The following is a description of a gene set: Mouse Gene Set: GOCC_COLLAGEN_CONTAINING_EXTRACELLULAR_MATRIX An extracellular matrix consisting mainly of proteins (especially collagen) and glycosaminoglycans (mostly as proteoglycans) that provides not only essential physical scaffolding for the cellular constituents but can also initiate crucial biochemical and biomechanical cues required for tissue morphogenesis, differentiation and homeostasis. The components are secreted by cells in the vicinity and form a sheet underlying or overlying cells such as endothelial and epithelial cells. species: Mus musculus, and this is the list of marker genes: Adamts17, Col28a1, Angpt4, Tgfb1, F3, Insl5, Nid1, S100a3, Pf4, Mfge8, Fga, Vwa1, Hapln4, Krt1, Fibcd1, Zp3, Efemp1, Adamts4, Adamts5, Agrn, Prss2, Spock2, Mfap5, Snorc, Vcan, Sparc, Bgn, Sparcl1, Anxa7, Postn, Fgfr2, Gpc2, Hnrnpm, Zg16, Abi3bp, Mfap1b, Rtbdn, Gpc4, Anxa4, Cela1, Dspp, Plod2, Ccn3, Il16, Lama3, Srpx2, Fgf10, Egfl7 (EGF-like domain 7), S100a11, Plod1, Adamtsl4, Ltbp1, Serpina3k, Lamb3, Mmp9, Hcfc1, Plxdc2, Serpinb1a, Htra1, Thbs4, Pzp, Rpsa, Pkm, Otol1, Ins2, Plscr1 (NCBI Gene Id 54533), Impg2, Sod3, Col14a1, Sftpa1, Matn2, Frem1, Adamts2 (NCBI Gene Id 327918), Col4a4, Ltbp3 (NCBI Gene Id 16998), Ctsb, Bmper (NCBI Gene Id 73230), Ncan, Ngly1, Lamc2, Tgm2, Mgp, Serpina1a, Lrrc15, Gpc1, Scara3, Muc2, Col24a1, Angptl1, Anxa6, Pcsk6, Itih2, Ambp, Aspn, Lgals1, Lama2, Col20a1, Serpine1, Tgm4, Col3a1 (collagen, type III, alpha 1), Cst3, Loxl3 (lysyl oxidase-like 3), Lamc1, Ctsc, Myoc, Ltbp4, Kng1, Mfap4, Emilin1 (elastin microfibril interfacer 1), Col17a1, Fn1, Cpn2 (carboxypeptidase N, polypeptide 2), Tgm3, Col4a3, Loxl1, Matn1, Reg2, Hsp90aa1, Fbn2, Col13a1, Gpc5, Tnn, Col6a6, Col7a1, Anxa9, Bmp7, Ecm1 (extracellular matrix protein 1), Comp, Sema3c (sema domain, immunoglobulin domain (Ig), short basic domain, secreted, (semaphorin) 3C), F13a1, Slit2, Gpc6, Tinagl1, Cspg4, Hmcn1, Vwf, Mfap1a, Igfbpl1, Hrg, Lum, Anxa2, Vwc2, Fam20b, Pcolce2, Tgfb3, Nid2, Cela3b, Adam19, Angptl6, Egflam, Col11a1, Bcan, Fbn1, Podnl1, Sspo, Adamts8, Serpinh1, Ctsd, Ctsl, Col8a1, Plod3, Ins1, Col23a1 (NCBI Gene Id 72794), S100a10, Lamb1, Igfbp7, Sftpb, Thbs3, Zp1, Emilin2 (elastin microfibril interfacer 2), Mmrn1, Dmbt1, Prelp, Wnt2, Loxl2, Cilp, Col9a1, Col12a1, Lgalsl, Lama4, Adamts1, Hmcn2, Reln, Lman1, Reg1, Col1a1, Prg4, Hspg2, Col4a2, F2, Tgfbi, Igf1, Col19a1, Calr, Angptl2, Tspan9, Lama1, Ccn1, Colq, Col10a1, Pxdn, Col11a2, Kazald1, Thbs1, Clec14a, Sftpd, Col6a1, Ccdc80, Nav2, Frem2, Serpine2, Tgfb2, Ctsz, Ecm2, Col4a1, Adamts10, Mamdc2, Muc1, Bmp1, Elane, Loxl4, Itih4, Ntn1, Itih1, Prg2 (NCBI Gene Id 19074), Try4, Npnt, Anxa3, BC037156, Itln1, Serping1, Chadl, Col6a4, Megf6, Hapln2, Angptl4, Hapln1, Angpt1, Dpt, Tnc, Fgl1, Col18a1, Efemp2, Dcn, Plxnb2, Adamtsl1, Fcnb, Col6a2, Col1a2, Col9a2, Anxa5, Adamts15, Col5a1, Cela2a, Matn3, Frem3, Amelx, Vtn, Angptl7, Col5a3, Col15a1, Thbs2, Smoc2, Ndp, Mfap2, Col25a1, Col6a3, Colec12, Eln, Ogn, Mmrn2, Vwa5a, Col4a5, Serpinf2 (serine (or cysteine) peptidase inhibitor, clade F, member 2), Itih3, Angpt2, Nepn, Gh, Itih5, Ltbp2, Serpinb6a (serine (or cysteine) peptidase inhibitor, clade B, member 6a), Tnr, Vit, Cstb, Reg3b, Serpini2, Sema6d, Igfbp6, Rbp3, Col5a2, Hapln3, Sfrp1 (NCBI Gene Id 72362), Lgals9, Tnxb (NCBI Gene Id 81877), Col4a6, Matn4 (matrilin 4), Col27a1, Spon1, Adam10, Fras1, Serpinc1, Plg, Igf2, Coch, S100a6, Anxa11, Fbln5, Plscr2, Ahsg, Col8a2, Lox, Col2a1, Lgals3, Impg1 (NCBI Gene Id 80684), Plxna2 (plexin A2), 2300002M23Rik, Reg3g, Lgals4, Acan, Clu, Fgl2, Zp2, Lama5, Muc4 (mucin 4), Fcna, Fgg, Lamb2, Fbln1, Ssc5d, Col6a5, Ptprz1, Emid1, Angptl3, Gpc3, Col16a1, Fmod, Fbln2, Papln, Fgb, Anxa1, S100a13